Given this list of marker genes HSP90AA1, CALR, HSPH1, SCARF1, HYOU1, APOB, here is a description of the gene set: Human Gene Set: REACTOME_SCAVENGING_BY_CLASS_F_RECEPTORS species: Homo sapiens Scavenging by Class F Receptors